Given this list of marker genes Dnajc30, Rrm2b, Hspa8, Selenon, Cfh, Zbtb20, Ndufs6, Atp6v1b2, Ucp2, Gapdhs, Myh6, Dnm1l, Pfkp, Uqcc3, Bcl2l1, Ndufv1, Atp5f1c, Ogdh, Ola1, Slc25a13, Ndufc1, Aldoart1, Tyms, Ldhd, Fam3a, Adcy10, Entpd4b, Atp5mc3, Guk1, Hkdc1, Oga, Gpi1, Dut, Ndufa1, Slc25a12, Pklr, Sdha, Atp6v1a, Prkaa2, Gpd1, Gck, Ak3, Gapdhrt2, Prkag2, Ppara, Nme7, Myc, Fignl1, Ep300, Ampd3, Ins2, Khk, Entpd7, Jmjd8, Nme2, Gtpbp1, Foxk1, Opa1, Ndufa3, Ak1, Eno1b, Slc2a6 (solute carrier family 2 (facilitated glucose transporter), member 6), Atp5po, Rhoa (NCBI Gene Id 51787), Pid1, Atp5f1a, Hspa1b, Ndufs7, Prkaca, Ndufab1, Sdhd, Pgam1, Galt, Psen1, Ndufs8, Igf1 (insulin-like growth factor 1), Nme1, Ndufs2, Mlx, Gapdhrt, Rab23, Ndufa2, Atp5f1d, Tpi1, Pfkfb3, Ncor1, Ndufb2, Myh3, Myh8, Abcc6, Atp5mf, Zbtb7a, Slc4a1, Mtch2 (mitochondrial carrier 2), Pgk2, Slc4a4, mt-Nd2, Stat3, Ak5, Atp5mg, Hk3, Cad (NCBI Gene Id 69719), Insr, Hk1, Ndufa11, Tbpl1, Dguok, Atp1b1, Ctps2, Ppp2ca (NCBI Gene Id 97777), Aldoart2, Pkm, Ndufb9, Impdh2-ps, Ndufb1, Src, Gnai3, Eno2, Sphk2, Nudt15, Ak4, Pgk1, Pfkfb2, Atp5f1e, Ndufa6, Atp5pd, mt-Atp8, Arl2, Atg5lrt, Pfkm, Aldoa, Ada, Ndufb5, Trem2, Gale, Atpsckmt (ATP synthase C subunit lysine N-methyltransferase), Sdhb (succinate dehydrogenase complex, subunit B, iron sulfur (Ip)), Flcn, Foxk2, App, Prkn, Sik2, Fkrp, Trex1, Fis1, Tspo, Rptor, Ppargc1a, Impdh2, Col6a1, Ndufv2, Hk2, Ins1, P2rx7, Gapdh, Ndufa10, Parp1, Atp5mc1, Ndufs4, Antkmt, Nme3, Trim63, Fbp1, Uchl1, Map2k1, Ndufb3, Ifng, Atp6-ps, Ndufa5, Ctns, Prkag1, Atp6v1b1, Dctpp1, mt-Nd6, Bend3, Ndufa9, Eno3, Atp5f1b, Esrrb, Bcl2l13, Ampd2, Cbfa2t3, Letmd1, Tkfc, Ctps1, Prkaa1, Gimap7, Cmpk2, Enpp1, Lrrk2, Eif6, Actn3, Prxl2c, Ndufa7, Atp1a2, mt-Atp6, Mfn1, Bad, Tigar, Git1, Atp5pb, Impdh1, Ndufv3, Mlxipl, Smpdl3a, Mtor, Stoml2, Vcp, Tgfb1, Uck2, Nudt16, Pfkl, Ndufb6, Tmsb4x, Dhtkd1, Kat2b, Prkag3, mt-Nd3, Nudt2, Parg (NCBI Gene Id 26430), Mlst8, Rhoq, Ier3, Atp5if1, Ogt, Hnf1a, Ndufs5, Ldhc, Ndufb11, Dmac2l, Entpd1, Slc25a25 (solute carrier family 25 (mitochondrial carrier, phosphate carrier), member 25), Efl1, Ak2, Uck1, Ran, Clpx, mt-Nd1, Mfsd8, Galk1, Ndufs3, Il4, Dtymk, Arnt, Cox11, Entpd4, Adpgk, Lipa, Hdac4, mt-Nd4l, Atp5me, Mpi, Htr2a, Nme6, Ndufc2, Pgam2, Ndufb8 (NCBI Gene Id 67264), Nme5, Eno4, Atp7a, Eno1, Sdhc, Nme4 (NCBI Gene Id 75413), Samhd1, Nupr1, mt-Nd5, Itpa, Hif1a, Atp5pf, Entpd3, Pfkfb1, Sirt6, Nt5e, Aldob, Nudt5, Ndufb7 (NCBI Gene Id 98326), Pnp, Ndufa13, Ndufa12, Nmnat1, Ndufa8, Ndufb10, Myog, mt-Nd4 (NCBI Gene Id 98546), Il3, Ndufs1, Abcc9, Ndufb4, Adk, Myh7, Enpp3, Aldoc, Bpgm, Atp5mc2, Bloc1s6, Ddit4, here is a description of the gene set: The chemical reactions and pathways involving a nucleoside triphosphate, a compound consisting of a nucleobase linked to a deoxyribose or ribose sugar esterified with triphosphate on the sugar. Mouse Gene Set: GOBP_NUCLEOSIDE_TRIPHOSPHATE_METABOLIC_PROCESS species: Mus musculus